Given this list of marker genes MICOS13, MICU1, CHCHD6, MICOS10, IMMT, APOOL, APOO, CHCHD3, here is a description of the gene set: A tubular structure of relatively uniform size that connects a mitochondrial crista to the mitochondrial inner boundary membrane. Human Gene Set: GOCC_MITOCHONDRIAL_CRISTA_JUNCTION species: Homo sapiens